Given this list of marker genes Lrp5, Fnta, Dok7, Sorbs1, Mesd, Sorbs2, Fzd9, Musk, Farp1, Crk, Lrp4, Ptn, Agrn, Crkl, Rac1, here is a description of the gene set: Mouse Gene Set: GOBP_REGULATION_OF_SKELETAL_MUSCLE_ACETYLCHOLINE_GATED_CHANNEL_CLUSTERING Any process that modulates the frequency, rate or extent of skeletal muscle acetylcholine-gated channel clustering. studied in species Mus musculus